The following is a description of a gene set: Agenesis of lateral incisor species: Homo sapiens Human Gene Set: HP_AGENESIS_OF_LATERAL_INCISOR, and this is the list of marker genes: NECTIN1, NAA10, LRP6, TGFA, BCOR, PAX9, EDARADD, AXIN2, DLX4, CDH1, ARHGAP29, WNT10B, FGFR1, EDA, BLM, COBLL1, WNT10A, MSX1, IRF6, B3GLCT, ARHGEF38, BMP4, TP63, PDGFRA, RIC1, DLG1, SUMO1, ERCC3